Given this list of marker genes ARID1B, EPC1, PTGER4, DRAM1, UBE2D2, NUFIP2, NSD1, MAGEB2, ZNF322, ATXN1L, RAET1E, SLITRK4, ZBTB40, NEO1, HTR2C, MRFAP1, CASP2, SV2B, EP300, ZNF117, WBP1L, IBTK, CACNA1C, ADGRG2, RICTOR, SLC6A8, DHRSX, ATXN7, ZNF20, UBN1, PDE4D, TMTC2, CDKL5, NABP2, TTBK2, C5orf24, CUX2, KCTD6, HYCC2, GXYLT1, ZNF652, PRPF40B, LIN28B, SH3TC2, RFX3, BCL2L10, PHF3, ZFP28, ZBTB4, ETAA1, ACSL4, RRM2, TANC2, AUTS2, ZNF225, SOX6, GPBP1L1, CNR1, KCNA4, ZNF740, SLCO1A2, EHF (NCBI Gene Id 26298), PLK2, KDM6B, OSER1, ASPH, INO80D (NCBI Gene Id 54891), GSTA4, PAK2, JPH3, BTN2A1, ZNF189 (NCBI Gene Id 7743), MLLT6, ENSA, SLC43A2, EEA1, RAD54L2, SOX21, ARHGEF9, KAT2A, TIA1, RGS4, ANKRD49, MMS19, MAP3K7CL, NEURL1B, MYLK2, ARHGEF28, DTNBP1, SORL1, TASOR, ITGAM, ATG10, CTNND2, SLC6A19, TXK (TXK tyrosine kinase), DCUN1D1, FOSB, COL1A2, MED6 (NCBI Gene Id 10001), S100A7A, LATS2, NRARP, CA12, MEX3A, ZEB1, ZNF329, FUT8, JADE1, FASTKD2, PDGFRA, PDE12, AGPAT4, N4BP2L1, CLCN6, ZNF568, PLEKHB2, TMEM35A, UCHL5, TGIF1, UPF1, ELAVL2, ID4, here is a description of the gene set: from publication Chen Y, Wang X (PMID 31504780) Genes predicted to be targets of miRBase v22 microRNA hsa-miR-342-3p in miRDB v6.0 with MirTarget v4 prediction scores > 80 (high confidence targets). studied in species Homo sapiens Human Gene Set: MIR342_3P